Given this list of marker genes Prkaa1, Pml, Pdk3, Cited2, Lmna, Vldlr, Mir146, Twist1, Reg1, Mir17, Nkx3-1, Egr1, Adipoq, Mir214, Pik3cb, Capn2, mt-Co1, Edn1, B3gat1, Aqp1, Cyp1a1, Usp19, Hyou1, Txn2, Smad3, Adrb2, Fam162a, Kdm6a, Tbl2, Epha4, Suv39h2, mt-Nd5, Ngb, Lonp1, Ero1a, Eef2k, Cybb, Ang2, Mir499 (NCBI Gene Id 735275), Chchd2, Src, Pak1, Cysltr1, Flt1, Zeb2 (NCBI Gene Id 319891), Lta, Uts2, Nf1, Sox4, Th, Alad, Abcc9, Mir222, Casp9, Mir199a-1, Prl4a1, Alkbh5, Plat, Mb, Mir21a, Foxo3, Nop53, Scn2a, Rptor, Srf, Map1lc3a, Atf4, Pdlim1, Ucp3, Aldh3a1, Lep, Eng, Prkce, Atm, Adora1, Nfe2l2, Bbc3, Ercc3, Arnt2, Ryr1, Suv39h1, Hp1bp3, Hif3a, Atp1b1, Nol3, Mmp2, Adm, Fosl2, Endog, Gngt1, Sod3, Ajuba, Higd1c, Myc, Tsc2, Egln1, Car9, Rwdd3, Mst1, Aqp3, Dnmt3a, Pin1rt1, Mir491, Ascl2, Angpt4, Ucp2 (uncoupling protein 2 (mitochondrial, proton carrier)), Tgfb2, Rgcc, Brip1, Sirt2, Sdhd, Cygb, Ireb2, Bcl2, Slc8a1, Il18, Bmp2, Egln3, Adam17, Angpt2 (angiopoietin 2), Ndp, Cbl, Abat, Myocd, Arnt, Drd1, Ppara, Cdkn1b, Limd1, Stc1, P2rx3, Cat, Mir199a-2, Trpv4, Apaf1, Usf1, Hilpda, mt-Cytb, Ang, Comt, mt-Nd4, Sox2, Nppc, Slc1a1, Agtrap, Stc2, Eno1b, Vegfc, Atf2 (activating transcription factor 2), Abcb1a, Pink1, Carlr, Itpr2, Ptprd (NCBI Gene Id 71786), Mtor, Becn1, Mir15b, Ubqln1, Bnip3l, Gata6, Bad (BCL2-associated agonist of cell death), Mir31, Egln2, Sod2, mt-Co2, Higd1a, Acaa2, Cryab, Pygm, Kcna5, Slc2a4, Pparg, Oprd1, P4hb, Aifm1, Hif1a, Angptl4 (NCBI Gene Id 57875), Mir327, Hmox1 (heme oxygenase 1), Eno1, Tfam, P2rx2, Fndc1 (NCBI Gene Id 68807), Drd2, Fzd4, Oxtr, Acvr2a, Mdm2, Raf1, Ado (NCBI Gene Id 211488), Il3, Casp3, Nono, Lct, Dio3, Slc6a4, Kcnk3, Ak4, Ang4, Vegfd, Ace, Ddr2, Mief1, Akt1, Ryr2, Ucn3, Grin2b, Dpp4, Hk2, Nr4a2, Pld2, Slc39a12, Kcnma1, Cbfa2t3, Kcnj11, Map2k1, Vasn, Ep300, Trh, Itpr1, Smad4, Mir207, Mt3, Scfd1, Pick1 (protein interacting with C kinase 1), Il1a, Camk2d, Adsl, Plau, Cysltr2, Cpt1a, Tgfb1, Tigar, Slc8a3, Cav3, Agtr1b, Ptk2b, F7, Acvrl1, Fos, Cr1l, Fabp1, Kcnj8, Bnip3, Mir204, Itga2, Hsd11b2, Mir874, Ager, Ada, Wtip, Ddah1, Pck1, Casr, Slc29a1, Ptgis, Casp1 (NCBI Gene Id 12362), Mapk8, Ptgs2, Kcnk2, Vegfb (NCBI Gene Id 22340, vascular endothelial growth factor B), Mir221, Plod1 (NCBI Gene Id 66472), Ciao3, Ptpn1, Mgarp, Tek, Cpeb4, Ccl2, Penk, Pgf, Dram1, Col6a1, Cryaa, Parp2, Prmt2, Scap, Loxl2, Mir379, Nos2 (nitric oxide synthase 2, inducible), Mir106a, Ece1, Trem2, Rad21, Hmox2, Hsp90b1, Wdr83, Rest, mt-Nd1, Pdk1, Bmyc, Daxx, Adam15, Ogt, Tm9sf4, Chrna4, Vegfa (NCBI Gene Id 22339), Ccna2, Fmn2, Postn, Mir142, Nfatc3, Cbs, Sirt4, Pdcd10, Rock2, Tacc3, Cpeb1, Mir20b, Birc2, Chrnb2, Epo, Lif, Rtn4, Epas1, Ercc2, Commd1, Alas2, Tsc1, Trp53 (transformation related protein 53), Tnf, Mir668, Plekhn1, Ang5, Zfp36l1, Zfas1, Prl8a2, Mecp2, Fundc1, Xrcc1, Gnb1, Vhl, Gad2, Ednra, Slc2a1, Kdr, Camk2g, Inhba, Mir150, Adam8, Stat3, Mir199b, Pin1, Tmbim6, Mstn, Ndnf, Chchd2-ps, Sirt1, Mmp14, Pgk1, Ddit4, Clca1, Tfrc, Kcnd2, Cd38, Ang6, Notch1, Tgfb3, Mlst8, Ppard, Rora, Eif4ebp1, Mir223, Sfrp1, Ndrg1, Dnm1l, Cav1, Slc9a1, Crhr1, Phb2, Cldn3, Cpeb2, Ccr2, Tert, Slc2a8, Acot2, Npepps, Pten, Cd24a, here is a description of the gene set: Mouse Gene Set: GOBP_RESPONSE_TO_DECREASED_OXYGEN_LEVELS studied in species Mus musculus Any process that results in a change in state or activity of a cell or an organism (in terms of movement, secretion, enzyme production, gene expression, etc.) as a result of a stimulus reflecting a decline in the level of oxygen.